Given this list of marker genes GTF2B, MICA, SYT11, KLHL7, ELOVL4, MERTK, TNFAIP6, RAB3IP, RB1CC1, FABP6, EFNB2, ARL4D, DENND3, DNAJC27, FOS, PMEL, CXCL8, LPIN1, NGFR, here is a description of the gene set: studied in species Homo sapiens Histone deacetylase (HDAC) inhibitors are expected to be effective for refractory cancer because their mechanism of action differs from that of conventional antineoplastic agents. In this study, we examined the effect of the HDAC inhibitor FK228 on malignant melanoma, as well as its molecular mechanisms. FK228 was highly effective against melanoma compared with other commonly used drugs. By comparing the gene expression profiles of melanoma cells and normal melanocytes, we defined a subset of genes specifically upregulated in melanoma cells by FK228, which included Rap1, a small GTP-binding protein of the Ras family. The expression of Rap1 mRNA and protein increased in FK228-treated melanoma cells in both a dose- and a time-dependent manner. A decrease in the phosphorylation of c-Raf, MEK1/2, and ERK1/2 was accompanied by an increase in Rap1 expression in both FK228-treated and Rap1-overexpressing cells. Inhibition of Rap1 upregulation by small interfering RNA (siRNA) abrogated the induction of apoptosis and suppression of ERK1/2 phosphorylation in FK228-treated melanoma cells. These results indicate that the cytotoxic effects of FK228 are mediated via the upregulation of Rap1. Furthermore, we found that Rap1 was overexpressed and formed a complex with B-Raf in melanoma cell lines with a V599E mutation of B-Raf. The siRNA-mediated abrogation of Rap1 overexpression increased the viability of these cells, suggesting that Rap1 is also an endogenous regulator of Ras-MAP kinase signaling in melanomas. Human Gene Set: KOBAYASHI_RESPONSE_TO_ROMIDEPSIN Genes up-regulated in MM-LH cells (malignant melanoma) after treatment with the HDAC inhibitor romidepsin (FK228). from publication Kobayashi Y, Ohtsuki M, Murakami T, Kobayashi T, Sutheesophon K, Kitayama H, Kano Y, Kusano E, Nakagawa H, Furukawa Y (PMID 16186804)